Given this list of marker genes Sirt3, Sirt2, Hdac11, Hdac3, Hdac2, Sirt4, Sirt7, Hdac4, Hdac5, Hdac1, Sirt1, Hdac9, Hdac6, Hdac8 (histone deacetylase 8), Sirt6, Hdac7, here is a description of the gene set: Mouse Gene Set: GOMF_HISTONE_H3K_DEACETYLASE_ACTIVITY Removal of an acetyl group from a lysine residue in a histone H3. species: Mus musculus